Given this list of marker genes PAFAH1B3, PCLAF, MCM10, BUB1B, NEK2, CCNE2, ESPL1, FANCI (FA complementation group I), CENPA, DPP3, CDC20, CKS2, CDKN2A, CENPU, SMC4, KIF23, DNA2, MAD2L1, IFT25 (intraflagellar transport 25), E2F1, H2AZ1, PBK, KIF15, LSM4, TMPO (NCBI Gene Id 7112), CENPM, DSG2, AURKB, TRIP13, MCM4, KIF11, SMC2, CDK1, SPAG5, NCAPH (non-SMC condensin I complex subunit H), STIL, CCNA2, CDCA8, PLK1, LMNB1, MCM2, DTYMK, DNMT3B, TYMS, PLEK2, KPNA2, CDC6, ANP32E, TPGS2, BIRC5, CELSR3, ERCC6L, HMMR, HJURP, SHCBP1, BRCA1, GTSE1, TMSB10, OIP5, ZWINT, RPA3, MYBL2, KIF18B, SPDL1, MAPK13, JPT1, KIF2C, HMGB2, EIF4EBP1, LRP8, TPX2, UBE2S, BID, KIF20A, FBXO5, CCNF, AURKA, TTK (NCBI Gene Id 7272), RAD51AP1, ASF1B, CENPF, CCNB1, SLC25A15, HELLS, ECT2, MCUB, SAC3D1, KIF4A, HMGA1, EBP, DTL, CHAF1B, CENPE, EZH2, KIFC1, NUSAP1, MKI67, TOP2A, MELK, PCNA, TK1, APOBEC3B, E2F8, KIF14, ACACA, DBF4, COMMD8, NCAPG, CDCA3, PTTG1, RRM2, DHFR, GMNN, GINS1, UBE2C, CA2, ASPM, SLC38A1, RACGAP1, CEP55, CHEK1, POLA2, FEN1, NDC80, NETO2, POLQ, GGH, TACC3, PRELID3B, MRPS15, KIF20B, PAQR4, PRC1, BUB1, CCNB2, DLGAP5, GINS4, ATAD2, H2AX, FOXM1, here is a description of the gene set: The 'Cervical Cancer Proliferation Cluster' (CCPC): genes whose expression in cervical carcinoma positively correlates with that of the HPV E6 and E7 oncogenes; they are also differentially expressed according to disease outcome. from publication Rosty C, Sheffer M, Tsafrir D, Stransky N, Tsafrir I, Peter M, de Crémoux P, de La Rochefordière A, Salmon R, Dorval T, Thiery JP, Couturier J, Radvanyi F, Domany E, Sastre-Garau X (PMID 16007141) Specific HPV DNA sequences are associated with more than 90% of invasive carcinomas of the uterine cervix. Viral E6 and E7 oncogenes are key mediators in cell transformation by disrupting TP53 and RB pathways. To investigate molecular mechanisms involved in the progression of invasive cervical carcinoma, we performed a gene expression study on cases selected according to viral and clinical parameters. Using Coupled Two-Way Clustering and Sorting Points Into Neighbourhoods methods, we identified a 'cervical cancer proliferation cluster' composed of 163 highly correlated transcripts. Most of these transcripts corresponded to E2F pathway genes controlling cell division or proliferation, whereas none was known as TP53 primary target. The average expression level of the genes of this cluster was higher in tumours with an early relapse than in tumours with a favourable course (P = 0.026). Moreover, we found that E6/E7 mRNA expression level was positively correlated with the expression level of the cluster genes and with viral DNA load. These findings suggest that HPV E6/E7 expression level plays a key role in the progression of invasive carcinoma of the uterine cervix via the deregulation of cellular genes controlling tumour cell proliferation. HPV expression level may thus provide a biological marker useful for prognosis assessment and specific therapy of the disease. Human Gene Set: ROSTY_CERVICAL_CANCER_PROLIFERATION_CLUSTER species: Homo sapiens